Given this list of marker genes MIR1-1, BMP10, PRKD1, MYLK3, EDN1, PROX1, here is a description of the gene set: Human Gene Set: GOBP_POSITIVE_REGULATION_OF_SARCOMERE_ORGANIZATION Any process that increases the rate, frequency or extent of myofibril assembly by organization of muscle actomyosin into sarcomeres. The sarcomere is the repeating unit of a myofibril in a muscle cell, composed of an array of overlapping thick and thin filaments between two adjacent Z discs. studied in species Homo sapiens